Given this list of marker genes SLC2A3, IRF6, TOMM40, SNCAIP, PTS, POLR3K, CCNF, PINK1, PPT1, PFN1 (NCBI Gene Id 5216), SNORD118, SPTLC1, WDR45 (WD repeat domain 45), RAB39B, MT-TL1, KCNQ3, HSD17B10, UBQLN2, ERBB4, KCNQ2, PRDX1 (NCBI Gene Id 5052), PDE10A, PLA2G6, CHCHD10, NUS1, HTRA2, TLR3, ZFYVE26, PRNP, NAGLU, PPP2R2B, CELF2, PRICKLE1, TRAK1, SLC13A5, PARS2, HNF4A, UBTF, MT-TE, SUMF1, DHDDS, ATRX, GALK1, FTH1, GIGYF2, ABCD1, SLC7A6OS, SZT2, FRRS1L, HCN1, EPM2A, PSAP, LRRK2, LMNB1, KCNA2, GOSR2, COMT, APTX, FBXO7, NOS3, CTC1, MT-TV, GCH1, CLN6, PRRT2, XPR1, LRPPRC, PSEN2, UBA5, MT-CYB, SCARB2, NBN, GABBR2, MT-ND5, ERCC2, MT-ATP6, NEK1, KARS1 (NCBI Gene Id 3735), RNF216, TIMM8A, UNC13A, ERCC6, KCNC2, ASAH1, PDGFRB, MT-TK, PLAU, MAPK10, CFAP43, POLG, CDK19, HTT, MT-TW, HGSNAT, ABCA7 (NCBI Gene Id 82843), CYFIP2, COL4A1, PRDM8, ACTL6B, MATR3, TP53, SLC44A1, NOTCH2NLC, SCN3A, CST3, CNTNAP2, CP, ATXN2, CERS1, GABRG2, ATP1A3, CACNA1A, SYNJ1, SCN1A, TSPOAP1, NDP (NCBI Gene Id 4693), EP300, MT-CO1, VPS13A, PARK7, TIA1, SYNGAP1, CDH23, SQSTM1 (NCBI Gene Id 94002), SNCB, PANK2, CPT1C, HLA-DQB1, VPS35, MME, APOE, MTHFR, HNRNPA2B1, COQ7, MTFMT, FBXO28, GABRB2, HEPACAM, PDGFB (platelet derived growth factor subunit B), TWNK, FIG4, SPG21, MT-ATP8, CHMP2B, RBM28, GDAP2, SPG11, GNAS, HTRA1, ATXN8OS, NOTCH3, ALDH18A1, VCP, PSEN1, FTL, USP8, DCTN1 (NCBI Gene Id 82109), CYP27A1, FOXG1, CTSF, DALRD3, MT-TH, NR4A2, PACS2, CLN8, PRKCG, CHI3L1, USP48, RTN4R, CSF1R, KCNC1, PMPCA, TYMP, COG2, NTRK2, COASY, CLN5, NECAP1, IDS, VAPB, SNCA, ARSA, MT-TT, CHD2, GABRB3, MT-ND6, OPTN, CACNA2D1, LYST, GLB1, FUS, KMT2A, FZR1, NR3C1, TAF15, JAM2, CTNS, SOD1, SLC1A3, PNPLA6, ITM2B, MAP2K1, MT-TF, L1CAM, AARS2, PLP1, NKX2-1, ANG, CLN3, PRKAR1A, CUX2, MFSD8 (NCBI Gene Id 256471), GABRA5, DRD3, MT-TS2, COX6B1, KIF1C, CYLD, CYC1, NRAS, TYROBP, APOL2, TREX1, SDHAF1, MT-CO3, GCDH, C9orf72 (NCBI Gene Id 73205), SLC38A3 (NCBI Gene Id 10991), TMEM106B, MICOS13, PODXL, DARS2, SCN8A, PLEKHG4, AP5Z1, TK2, ADH1C, SLC20A2, C19orf12, NPC1, TRPM7, CTSD (NCBI Gene Id 196214), HEXB, GBA1, MPO, GPRC5B, ATXN10, KCTD7, CREBBP, GRIN2D, TTPA, ATP1A2, ATP6V0A2, PRKAR1B, FGF12, CUBN, MT-TQ, HTR2A, NPC2, SDHD, TUBA4A, FMR1, PAH, ERCC4, SLC13A3, GRIN2A, MBTPS2, ACTB (NCBI Gene Id 60), FUCA1, AP3B2, AMACR, SLC1A2, DGUOK, CARS2, HMBS, SMPD1, RRM2B, GRN, TARDBP, PRPH (peripherin), GM2A, STARD7, APOL4, CACNA1B, VPS13C, SAMD9L, ANXA11, DLAT, ATP7B, MT-CO2, CLTC (NCBI Gene Id 9511), APP, RNASEH1 (NCBI Gene Id 246243), WFS1, PPARGC1A, MAPT, EEF1A2 (eukaryotic translation elongation factor 1 alpha 2), RNU4ATAC, PRKN, DAO, NDUFA1, GALC, DNMT1, TBK1, PON3, GLT8D1, MFN2, GLE1, GABRA2, CSTB (NCBI Gene Id 1476), AUH, GBA2, PDE11A, SGPL1, EIF4G1, MT-ND1, AASS, PON2, CHCHD2, PON1, ATP13A2, MECP2, TBP, CNKSR2 (NCBI Gene Id 22866), NHLRC1 (NHL repeat containing E3 ubiquitin protein ligase 1), ABCB7, XPA, DNAJC13, FA2H, BRAF, AGK, YWHAG, NEFH (neurofilament heavy chain), JPH3, HEXA, STUB1, BSCL2, DAOA, DNM1L, ATN1 (NCBI Gene Id 1822), LIG3, TIMMDC1, DNAJC5, NDUFA6, KCNB1, IDUA, UBAP1, CISD2, WWOX, MT-TC, ADA2, RAB27A, ATP6V1E1, DNAJC6, SLC39A14, EIF2B5, MMACHC, MCOLN1, ERCC8, SPAST (NCBI Gene Id 6683), ROGDI, PPP3CA, TUBB4A, HIBCH, MYORG (myogenesis regulating glycosidase), SDHB, HNRNPA1, SORL1, GBE1, QDPR, DNM1, TMEM240, TTR, SERPINI1, SCN2A, ATXN3 (ataxin 3), GALT, OPA1, SYN2, ATXN7, ATP6V1A, TINF2, MT-ND4, SDHA, TREM2, AARS1, UCHL1, CFAP410, here is a description of the gene set: species: Homo sapiens Human Gene Set: HP_MENTAL_DETERIORATION Loss of previously present mental abilities, generally in adults. Mental deterioration